Given this list of marker genes PACS1, PLXNA1, ZBTB4, MEN1, NMD3, CLDND1, ZNF672, FBXL16, PCDHGA9, MTCL2, PARVG, GNG13, SMPD3 (NCBI Gene Id 79756), ABCF1, SRSF7, ARRB1, GNAI2, TYSND1, MPZL2, RPIA, KIF21B, JMJD8, NKAIN2, ACVRL1, RNF20, NFIC, SH3PXD2A, PRLHR, ZNF346 (NCBI Gene Id 23567), PCDHGA4, NAA60, EFNB3 (NCBI Gene Id 1949), LIFR, TOX2, PCDHGA7, SEPSECS, PCDHGA8, PPM1M, ERC1, TRMT61A, NKIRAS2, YY1AP1, SLC8A2, SYT7, NECTIN1, KLK4, NCS1, GSK3A, PMM2, HOXA7, CRTC1, SH3PXD2B, SLC45A2, GRIK3, MFAP1, DCANP1, CLDN19, PCDHGB2, MAP6D1, SDK2 (sidekick cell adhesion molecule 2), WHRN, PAQR4, PHLDB1, TRAF1, CTCF, CYP26B1, TLX1, SHB, PKLR, ZNF609, GPRIN1, RAB6B, TBL1XR1, IGSF8, LARP1, ZFR2, BCAM, PRKACA, SAMD11, TAOK2, CLIP2, GAB1, PCDHGC3, PCDHGB6, OLFML2A (NCBI Gene Id 169611), PAX7 (paired box 7), HSPB6, PKIG, SEMA6A, STK40, TTYH3, KCNS1, TMCC3, SLC9A3, APC2, ACVR1B, ENG, VDR, SLC6A17, GPBP1L1, ARMC3, DENND2B, EEFSEC, PCDHGC5, CLCNKB, PROM2, NPTX1, ZNF395 (NCBI Gene Id 55893), PLXDC2, SPOCK2, PPP3R2, MPRIP, MYO1C, TRAF7, NFIX, WARS1, MID2, PCDHGB4, NDRG4, TRPM3, SLC12A4, NCOR1, SON, PCDHGA2, PCDHGA5, CPLX2, ACE, CAPN15, PCDHGA11 (NCBI Gene Id 93062), PCDHGA6, PRAF2, PSME3IP1, RAB35, ARHGAP1, PCDHGC4 (protocadherin gamma subfamily C, 4), SLC1A3, BTF3L4 (basic transcription factor 3 like 4), GFI1, BPTF, CLIP3, NAP1L3, FBXO41, SYNDIG1L, CDYL2, NATD1, MECP2, ZDHHC22, PPIL2, ARL2BP, TMEM178B, ADGRL1, SRD5A1, CPEB3, CLDN18, PCDHGA3, TTL (tubulin tyrosine ligase), CBX7, ATP2B2, GRM2, SYNJ1, AKT3, SZT2, PCDHGA12, GIPC3, PKP2, PTCD1, AP5B1, CDC42SE1, BHMT2, CLCN5, PPP1R11, IQSEC2, MDGA1, LRRC4B, ST3GAL1, RPL28, PARN, PCDHGB3, STUM, COPS7B, KIAA0930, ARNT2, SNX19, TTLL6, CX3CL1 (NCBI Gene Id 6376), RAB5A, FAM219A, DNAJB5, PCDHGB5, PCDHGA1, PEX14, TRAPPC9, SLC2A8, LMF2, LZTS1 (leucine zipper tumor suppressor 1), EIF5, PTPRF, CASP10 (NCBI Gene Id 843), EVC, SLC35F5, CPLX3, ACTMAP, CNIH2, CPNE2 (copine 2), ABCF2, CLCF1, TM2D3, CPSF7, CDR2L, ZNF219 (NCBI Gene Id 54166), TNC, CUEDC1, UBA1, PPP1R16B, RELT, ITCH (NCBI Gene Id 83737), EPHB2, AOC3, MBTD1, PCDHGA10, PCDHGB7, BTBD9, RAP1GAP2, WDR48, TAGLN, OSBP2, CERS1 (NCBI Gene Id 10715), PML, PDE4D, OTOF, GLIS2, SEMA7A, ATP5MF-PTCD1, PPM1H, LRP1, JPH3, PPIE, KCNIP3, CNP, IGFBP5, ARID3B, BCL2L13, KIAA0513, VAMP1, TMEM41A, STRBP, REXO1, PCDHGB1, APLN, SDC3, here is a description of the gene set: Human Gene Set: MIR4498 from publication Chen Y, Wang X (PMID 31504780) Genes predicted to be targets of miRBase v22 microRNA hsa-miR-4498 in miRDB v6.0 with MirTarget v4 prediction scores > 80 (high confidence targets). studied in species Homo sapiens